The following is a description of a gene set: species: Homo sapiens Enables the directed movement of a xenobiotic from one side of a membrane to the other. A xenobiotic is a compound foreign to the organism exposed to it. It may be synthesized by another organism (like ampicilin) or it can be a synthetic chemical. Human Gene Set: GOMF_XENOBIOTIC_TRANSMEMBRANE_TRANSPORTER_ACTIVITY, and this is the list of marker genes: SLC22A2, ABCA3, SLC19A1, ABCC10, SLC46A1, ATRAID, ABCB1, ABCB5, ABCC11, SLC47A2, SLC2A1, SLC37A3, ABCB11 (ATP binding cassette subfamily B member 11), ABCC1, ABCG2, SLC22A8, SLC18A1, ABCA8, SLC17A3, SLC47A1, SLC22A1, SLC29A4, SLC22A6, RALBP1, ABCC4, ABCC3, ABCC2, SLC43A3, ABCC5, SLC22A18, SLC31A1, SLC22A5